Given this list of marker genes POLD2, POLQ, POLH, POLK, REV3L, PRIMPOL, REV1, POLI, USP1, MAD2L2, POLD3, POLE2, here is a description of the gene set: species: Homo sapiens The conversion of DNA-damage induced single-stranded gaps into large molecular weight DNA after replication by using a specialized DNA polymerase or replication complex to insert a defined nucleotide across the lesion. This process does not remove the replication-blocking lesions and causes an increase in the endogenous mutation level. For example, in E. coli, a low fidelity DNA polymerase, pol V, copies lesions that block replication fork progress. This produces mutations specifically targeted to DNA template damage sites, but it can also produce mutations at undamaged sites. Human Gene Set: GOBP_ERROR_PRONE_TRANSLESION_SYNTHESIS